The following is a description of a gene set: Any process in an organism that results in the killing of its own cells or those of another organism, including in some cases the death of the other organism. Killing here refers to the induction of death in one cell by another cell, not cell-autonomous death due to internal or other environmental conditions. Human Gene Set: GOBP_CELL_KILLING species: Homo sapiens, and this is the list of marker genes: PVR, IL4, LYZ, RAET1G, NCR3, NECTIN2, CCL19, GNLY, KLRC1, CTSH, CCL28, HLA-F (major histocompatibility complex, class I, F), CORO1A, CD1D, STAP1, CD2, MAPK8, NPPB, SCNN1B, CCL11, CEACAM1, UNC13D, IL12A, GSDMB, LTF, CFHR2, CLEC12B, KLRC3, CLEC2A, CXCL14, TOR2A, KNG1, CXCL1, PIK3R6, HMGN2, IL10, TGFB1, FCGR3B, PGLYRP1, ITGAM, RAET1L, CRK, CEBPG, ARG1 (NCBI Gene Id 383), IL7R, CFHR1, NTS, DEFA4, IL13, MUC7, PGLYRP3, CXCL10, PF4, MYD88, CXCL12, MICA, PPP3CB (NCBI Gene Id 5532), SH2D1A, PIK3R1, ROMO1, GRB2, HLA-E, H2BC12, ARRB2, B2M, C6, RPL30, CD226, PRDX1, LAMP1, C3, CFH, CD1A, C8A, RAB27A, TUBB4B, PLA2G2A, RIPK3, CRTAM, MICB, HLA-DRA (major histocompatibility complex, class II, DR alpha), CCL22, LCE3C, CAMP, DEFB132, FCGR2C, STAT5B (signal transducer and activator of transcription 5B), LAG3, FCGR1BP, INPP5D, KIR2DL4, HLA-H, TAP2, GBP3, NCF1, FCGR3A, CXCL9, ULBP3, F2RL1, LILRB1, TGFB2, NLRP6, H2BC11, CCL25, DEFB118, CCL1 (NCBI Gene Id 6346), DEFB4A, TREM1, GZMA, CST11, CD160, IGHE, DNASE1L3, SERPINB4, FCGR2A, HLA-B, ICAM1, CCL21 (NCBI Gene Id 6366), IL12RB1, HLA-C, CCL18, VAMP7 (NCBI Gene Id 6845), HLA-DRB1, P2RX7, EMP2, CCL8, KIF5B, TIGIT, IL18, KIR3DL1, EBAG9 (estrogen receptor binding site associated antigen 9), CD5L, C7 (NCBI Gene Id 636878), CR1, HAMP, C8G (complement C8 gamma chain), LYZL6, FCGR1A, IGHG1, CTSC, IL23R, HRG, DAO, SLAMF6 (SLAM family member 6), CXCL6, FCGR2B, CFHR5, DEFB136, KLRK1, MR1, HTN3, PIK3CB, RASGRP1, AP1G1, STXBP2, DEFA5, DCD, RPS19, CCL17, NKG7, GBP2, CADM1, LCE3B, HLA-G, IL21, SLAMF7, HLA-A, S100A12, PTPRC, TAC1, XCL1, SEMG1, PRF1 (NCBI Gene Id 5551), ARL8B, CXCL8, TUBB, CCL13, CYRIB, VAMP2, KLRB1, NOS2 (NCBI Gene Id 4843), IL23A, PTPN6, KLRC4-KLRK1, CD59, KLRC2, DNASE1, CD55, CCL20 (NCBI Gene Id 6364), DEFA6, GZMM, CCL27, TUSC2, CHGA, GBP5, CXCL11, DEFB130A, ULBP2, DEFB103B, DEFB103A, GBP1, LGALS3, GZMB (NCBI Gene Id 3002), NECTIN4, APOL1 (apolipoprotein L1), KLRC4, LEP, AZGP1, CTSG, KRT6A, DEFA3, TYROBP, CR1L, CXCL3, NCR1, NCKAP1L, DEFA1B, PGLYRP4, LCE3A, SERPINB9, C5, MBL2, HCST, PCYOX1L, DEFB128, KLRF2, HTN1, NINJ1, CD1C, SLC22A13, STX7, SPAG11B, C9, GFUS, CD1E, CD1B, ELANE, IL18RAP, RNASE7, PLEKHM2, C8B, GAPDH, CXCL13, GBP7, VAV1, DEFA1, CX3CR1 (NCBI Gene Id 2836), RAET1E, PPBP, STAT5A, POMC, LYST, HPRT1, IL11, F2, ULBP1, FADD, AZU1, IL12B, AGER, RNF19B, ATN1, LGALS9, KLRD1, SPI1, HAVCR2, CXCL2, GZMH